Given this list of marker genes Syk, Kmt5b, Nbn, Ifnz, Lgals3, Brd2, Pglyrp1, Sanbr, Kmt5c, Hmgb1, Gata2, Il27ra, Vamp2, Gm13275, Gpr183, Ticam1, Myo1f, Aicda, Clcf1 (cardiotrophin-like cytokine factor 1), Itfg2, Abr, Kars1, Myb, Gata3, Mfng, Ifnk, Ceacam1, App, Socs5, Pram1, Ifna14, Irf1, Ptprc, H2-DMb2, Zfp35, Trp53, Atad5, Ifne, Pck1, Milr1, Nr4a3, Gbf1, Mir181b-2, Smad7, Tnfsf4, Notch2, Spn, Tbk1, Sh2d1b1, Ccr6, Spi1, Apbb1ip, Jak3, Mrgprb1, Abl1, Ep300, Bcl6, Ighe, Cx3cr1, Icam1, Ptpn6, Gm13271, Lbp, Mir873a (NCBI Gene Id 100124457), Ifna6, Slamf1, Nfkbiz, Swap70, Cplx2 (NCBI Gene Id 12890), Tmem98, Parp3, Fcer1a, Tlr4, Xrcc4, Nkg7, Pglyrp2, Pikfyve, Anxa3, Nmi, Gm13277, Muc19, Loxl3, Stat3, Hmces, Ccl3, Nkx2-3, Malt1, Lat, Gm13283 (predicted gene 13283), Plcl2, Exosc6 (exosome component 6), Unc13d, Grn, Ifna13, Lfng, Slamf6, Mtor, Trem2, Enpp3, Tnfaip3, Lcp1, Slc15a4, Lrp1, Rora, Dock2, Ifna1, Brd4, Cd177, Cd244a, H2-DMb1, Ptk2b, Lamp1, H2-Ea, Gm13272, Rab44, Bcl3, Ifnab, Il4, Il6, Cdh17, Trex1, Tfrc, Rab27a, Mir301, Ccr7, Psen2, Rnf8, Ndfip1, Scnn1b, Nppc, Lilrb4a, Lyn, Itgb8, Icosl, Gapt, 6030468B19Rik, Nckap1l, Rc3h2, Gadd45g (growth arrest and DNA-damage-inducible 45 gamma), Ccr2, Itgb2l, Kmt2a, Bcr, Stxbp3, Adora2b, Msh2, Stat6, Nlrp3, Gpr15lg, Lat2, Il27, Tyrobp, Tsc1, Gm13276, Pdpk1, Fcer1g, Btk, Snx4, Rnf168, Stxbp2, Trp53bp1, Ifnb1, Rasgrp1, Ercc1, Pms2, Ifng, Rac2, Coro1a (coronin, actin binding protein 1A), Ada, Pycard, Ifna2, Cbl, Adora3, Aplf, D6Wsu163e, Chga (NCBI Gene Id 12652), Otud5, Il12b, Foxp1, Pla2g3, Exosc3, Fgl2, Hmox1, Zbtb7b, Rif1, Lypd10, Itgb6, Irf8, Paxip1, Gata1, Scn11a, Cd19, Rps6, Batf, Pi4k2a (phosphatidylinositol 4-kinase type 2 alpha), Il18, Ddrgk1, Psen1, Dock10, Ripk2, Fes, Shld2, Pagr1a, Il18r1, Hspd1, Mir181b-1, Pglyrp3, Ms4a2, Hlx, Fcgr4, Zfp683, Men1, Cd40, Atp7a, Lgals1, Rara, Tnfsf13, Sucnr1, Itm2a, Sphk2, Cd160, Il33, St3gal1, Relb, Shb, Enpp1, Slc18a2, Ap1g1, Rorc, Il2, Cd40lg, H2-M3, Ifna12, Sema4a, Kit (KIT proto-oncogene receptor tyrosine kinase), Cd81, Ccl19, Shld1, Ifna4, Fgr, Cd84, Rc3h1, Pglyrp4, Mlh1, Tbx21, Cd28, Havcr2, Rag2, Phf14, Supt6, F2rl1, Ccl20, Stxbp1, Dnase1, Grp, Tac4, Crhr1, Ifna9, Lypd11, Fer, Lgals8, Eomes, Ptgdr, Tcim, Lgals9, Stx4a, Cracr2a (calcium release activated channel regulator 2A), Clnk, Slc11a1, Clec4d, Sema6d, Itgal, Ascl2, Ifna15, Plcg2, Xbp1, Il13, Il6ra, Zc3h12a, Clec7a, Foxf1, Foxp3, Ifi35, Msh6, Itgam, Dysf, Ywhaz, Plxna1, Vamp8, Ptafr, Nsd2 (NCBI Gene Id 77281), Il13ra2, BC037156, Pik3r1, Prkcz, Dock11, Ifna11, Ifna5, Il23a, Cd180, Itgb2, Stat4, Il10, Ung, Slfn2, Gkn2, Nfkbid, Cd74, Ifna7, Sbno2, Ptgds, Exo1, Tgfb1, Eif2ak4, Ifna16, Mad2l2, Irf4, Lef1, Lig4, Cd69, Gab2, Mrgprx2, Nppa, Mdk, Entpd7, Prkce, Pf4, Dnase1l3, Shld3, Mir326, Tnf, Clec4e, Pld2, Il4ra, Kctd9, Rabgef1, Tnfsf18, Opa1, Pcyt1a, Cd46, Dll1, Ly9, Stx11, Pou2af1, Anxa1, Snap23, Il21, Ptger4, Myd88, Cd300a, here is a description of the gene set: species: Mus musculus A change in the morphology or behavior of a cell resulting from exposure to an activating factor such as a cellular or soluble ligand, leading to the initiation or perpetuation of an immune response. Mouse Gene Set: GOBP_CELL_ACTIVATION_INVOLVED_IN_IMMUNE_RESPONSE